Given this list of marker genes Fmo3, Mfsd2a, Cfd, Ptgds, Rtn4, Acot1, Cux2, Cyp4a14, Xist, Acot3, here is a description of the gene set: Genes commonly down-regulated in both non-tumorous and tumorous liver tissues of PARK2 knockout mice. studied in species Mus musculus from publication Fujiwara M, Marusawa H, Wang HQ, Iwai A, Ikeuchi K, Imai Y, Kataoka A, Nukina N, Takahashi R, Chiba T (PMID 18574468) Mouse Gene Set: FUJIWARA_PARK2_HEPATOCYTE_PROLIFERATION_DN The parkin was first identified as a gene implicated in autosomal recessive juvenile Parkinsonism. Deregulation of the parkin gene, however, has been observed in various human cancers, suggesting that the parkin gene may be important in tumorigenesis. To gain insight into the physiologic role of parkin, we generated parkin-/- mice lacking exon 3 of the parkin gene. We demonstrated here that parkin-/- mice had enhanced hepatocyte proliferation and developed macroscopic hepatic tumors with the characteristics of hepatocellular carcinoma. Microarray analyses revealed that parkin deficiency caused the alteration of gene expression profiles in the liver. Among them, endogenous follistatin is commonly upregulated in both nontumorous and tumorous liver tissues of parkin-deficient mice. Parkin deficiency resulted in suppression of caspase activation and rendered hepatocytes resistant to apoptosis in a follistatin-dependent manner. These results suggested that parkin deficiency caused enhanced hepatocyte proliferation and resistance to apoptosis, resulting in hepatic tumor development, partially through the upregulation of endogenous follistatin. The finding that parkin-deficient mice are susceptible to hepatocarcinogenesis provided the first evidence showing that parkin is indeed a tumor suppressor gene.